Given this list of marker genes CCN2, PDGFA, TGFB1, HGF, IGF1, PTGS2, ANGPT2, ANGPT1, here is a description of the gene set: Human Gene Set: GALIE_TUMOR_ANGIOGENESIS Angiogenic genes up-regulated in A17 carcinomas (high vascularization) compared to the syngeneic BB1 and spontaneous tumors (little vascularization). Tumor microenvironment in carcinomas recruits mesenchymal cells with an abnormal proangiogenic and invasive phenotype. It is not clear whether mesenchymal tumor cells (MTCs) derive from the activation of mature fibroblasts or from their stem cell precursors. However, stromal cell activation in tumors resembles in several aspects the mesenchymal rearrangement which normally occurs during reparative processes such as wound healing. Mesenchymal stem cells (MSCs) play a crucial role in developmental and reparative processes and have extraordinary proangiogenic potential, on the basis of which they are thought to show great promise for the treatment of ischemic disorders. Here, we show that MTCs have proangiogenic potential and that they share the transcriptional expression of the best-known proangiogenic factors with MSCs. We also found that MTCs and MSCs have the same molecular signature for stemness-related genes, and that when co-implanted with cancer cells in syngeneic animals MSCs determine early tumor appearance, probably by favoring the angiogenic switch. Our data (1) reveal crucial aspects of the proangiogenic phenotype of MTCs, (2) strongly suggest their stem origin and (3) signal the risk of therapeutic use of MSCs in tumor-promoting conditions. studied in species Mus musculus from publication Galiè M, Konstantinidou G, Peroni D, Scambi I, Marchini C, Lisi V, Krampera M, Magnani P, Merigo F, Montani M, Boschi F, Marzola P, Orrù R, Farace P, Sbarbati A, Amici A (PMID 17998939)